The following is a description of a gene set: Human Gene Set: FOXO3_01 species: Homo sapiens Genes having at least one occurrence of the motif TNNTTGTTTACNTW in the regions spanning 4 kb centered on their transcription starting sites. This matches the FOXO3A transcription factor binding site V$FOXO3_01 (v7.4 TRANSFAC)., and this is the list of marker genes: AP4M1 (adaptor related protein complex 4 subunit mu 1), MCM7 (NCBI Gene Id 4176), PITX2, IRF4, CDK11A, NNAT, CTLA4, FOXP2 (forkhead box P2), FBXO9, HOXB8, TENM1, STC2, COL8A1, NXPH3, ZEB2, ELOVL6, BIN1, C12orf50, TMEM71, PSMA8, HIBADH, CSRNP3, NDST4 (NCBI Gene Id 64579), SALL3 (NCBI Gene Id 27164), PDE7A, HAS2, PHTF2, TPP1, RXRB, CHD6, IKZF4, ARID4A, BRAF, SOX12 (SRY-box transcription factor 12), OTULINL, MBNL1, NKX2-1, SERINC3, RBFOX1, PAX6, GRB7, WBP1L, GFI1B, CLC, SMAD5, SCUBE3, LIX1L, PLEKHA5, WIPI2, AP1G2, TXNDC12 (NCBI Gene Id 51060), HTN1, BUB3, LCP2, HMCN1, MAFF, TSPAN33, DOCK4, JMJD1C, SUMO1, KDM6A, ARFIP1, MBNL2, TRIM8, CFAP91, ITGA3, NTRK3, NEDD4, FSBP, FAM53C, PURA, ACACA, SREK1, NR1D1, DTNA, PHF21A, PTCH1, EFCAB3, AKIRIN2, TJP1, C1QTNF7, TGFB3, ENPP2, PMCH, CACNG2, PALS2, SEMA3A, TFAP4, ZBTB22, MAPK10 (NCBI Gene Id 5602), CILK1, LDB2, PDZRN4, SCRN3, FBXL22, IMPDH2, MRGPRF, ATF2, KLHL40 (kelch like family member 40), ZNF362, PTGR3, BCL11B, NMNAT2, CNNM3, FGF9, NRAS, KLF12, FOXD3, PRKCI, GFRA1, CHCHD7, SH3RF1 (SH3 domain containing ring finger 1), UBE2H, VCPKMT, FBXW4, PNLIPRP2 (NCBI Gene Id 5408), FOXO1, CPVL, NR3C2, FUZ, PCDH18, CLIP2, TTR, NRN1L, UTP25, RARB, DLX2, HS3ST1, CFL2, ETV5 (ETS variant transcription factor 5), STOML3, NFIB (NCBI Gene Id 4781), PDK4, UPK1B, IL1RAPL1, SLC38A3, WDR46, CREBL2, RSF1, POLR2L, DIXDC1, FGF12, IL21, PPP1CB, PDGFRB (NCBI Gene Id 5159), EFNA1, CDK14, LMO3, PKN2, BDNF, HR, KITLG, PFDN6, TIGD4, VSIG2, PLAG1, NSD3, EAPP, SH2D4A, AKT1S1, JUNB, GTF2B, SHOX2, BMI1, BRD8, SKAP1, CRH, HBP1 (HMG-box transcription factor 1), NTN1, TBC1D17, BCLAF3, EZH1, LRP5, PHLPP1, CLPX, KIF20A, CACNA2D1, GTF2A1L, PELI2, CDK11B, CDKN1C, TEX2, RFX3, NUB1, COLEC10, PRDM1, AAMDC, STARD13, SYT6, PTCHD1 (patched domain containing 1), UBR5, IKZF2, TSPAN4, ID2, VPS26A (VPS26 retromer complex component A), ULK1, NXN, TRIM63, RBP2, HLX, DLL1, RTL9, BCL7A, NRG1, SLC39A7, LINC03122, LARP7, ABTB1, GSX1, PRKAG1, JADE2, UTY, ZNF521, ZBTB18, SNCAIP, CHD2, AQP2, TBX4, TNRC6A, CADM1, TTC33, OMD, POU3F4, KCNJ5, ZNF277, MEIS2, OTX2, DDIT4, RETREG1, CREBRF, PDCD4, LAG3, LHX9, SRSF7, FOXB1, ZMAT4, CNTF, SLITRK6, MIDEAS, NFIX, ASTN1, ZFAND2A, SQSTM1, SELENOP, LINC00173, TAL1, TBL1X, EGR2, FRY, TRPC4, CITED2